Given this list of marker genes CYP1A1, CAT, F7, BGLAP, UGT3A2, CEBPA, here is a description of the gene set: studied in species Homo sapiens Human Gene Set: GOBP_RESPONSE_TO_PHENYLPROPANOID Any process that results in a change in state or activity of a cell or organism (in terms of movement, secretion, enzyme production, gene expression, etc.) as the result of a phenylpropanoid stimulus. The process begins with detection of the stimulus and ends with a change in state or activity or the cell or organism. A phenylpropanoid is any of secondary metabolites with structures based on a phenylpropane skeleton. The class includes phenylpropanoid esters, flavonoids, anthocyanins, coumarins and many small phenolic molecules. Phenylpropanoids are also precursors of lignin.